The following is a description of a gene set: The progression of a glandular acinus of the prostate gland over time, from its initial formation to the mature structure. The glandular acini are the saclike structures of the gland. species: Homo sapiens Human Gene Set: GOBP_PROSTATE_GLANDULAR_ACINUS_DEVELOPMENT, and this is the list of marker genes: FRS2, FOXA1, WDR77, ESR1, HOXB13, SFRP1, NOTCH1, HOXD13, TP63, FGFR2, IGF1